Given this list of marker genes BMP4, EDNRA, BMP7 (bone morphogenetic protein 7), EDN1, ENG, SEMA3C (NCBI Gene Id 222200), TWIST1, FOLR1, CDC42, PITX2, HAND2, here is a description of the gene set: Human Gene Set: GOBP_CARDIAC_NEURAL_CREST_CELL_MIGRATION_INVOLVED_IN_OUTFLOW_TRACT_MORPHOGENESIS species: Homo sapiens The orderly movement of a neural crest cell from one site to another that will contribute to the morphogenesis of the outflow tract.